Given this list of marker genes OPTN, NR1D1, LILRB4, PPM1B, NLRP12, CYLD, DNAJA3, RHOH, AZI2, SLC39A8 (NCBI Gene Id 64116), MIR15A (microRNA 15a), MIR27A, MIR138-1, MIR21 (NCBI Gene Id 406991), CD200, KLF4, TGFBR3, FAF1, TREM2, NR1H4, OLFM4, PER1, CACTIN, SBNO1, GSTP1, RIPK1, TRIM39, ADIPOQ, RORA, IRAK1, TNFAIP3, CHRNA7, MIR140, HDAC1, IRAK2, USP20, PIAS4, ANXA4, ITCH (NCBI Gene Id 83737), ESR1, SNIP1 (NCBI Gene Id 79753), MIR195, SIRT1, NLRP6, MAPKBP1, TNIP3, STAT3, DAB2IP, PPP2CB, STAT1, SIVA1, PYCARD, NFKBIL1 (NCBI Gene Id 4795), MIR146A, NLRC3, USP10, NKIRAS2, CASP8, CCDC22, CARD8, TAX1BP1, SPI1, TMSB4X, TRIM59, TANK, MIR30C2, OTUD7B, MIR497, IRGM, NLRX1, MIR199A1, IRAK3, NFKBIA, MIR16-1, PPM1A, TNIP2, PYDC1, MIR15B, MAP2K5, ZC3H12A, MIR365A, RIOK3, TLE1, ARRB2, TMC8, TNIP1, CARD19, NKIRAS1, TSPAN6, ZMYND11, ZNF675, SIRPA, here is a description of the gene set: Human Gene Set: GOBP_NEGATIVE_REGULATION_OF_CANONICAL_NF_KAPPAB_SIGNAL_TRANSDUCTION species: Homo sapiens Any process that stops, prevents, or reduces the frequency, rate or extent of a canonical NF-kappaB signaling cascade.